The following is a description of a gene set: A recycling endosome of the postsynapse. In postsynaptic terminals with dendritic spines, it is typically located at the base of a dendritic spine. It is involved in recycling of neurotransmitter receptors to the postsynaptic membrane. In some cases at least, this recycling is activated by postsynaptic signaling and so can play a role in long term potentiation. species: Homo sapiens Human Gene Set: GOCC_POSTSYNAPTIC_RECYCLING_ENDOSOME, and this is the list of marker genes: VPS26B, AKAP5, AP3M1, ZDHHC2, ABHD17B, TFRC, STX12, RAB11A, SNX27, ABHD17A, RAB11FIP3